The following is a description of a gene set: In normal human plasma, thrombin cleaves factor VIII (FVIII) after arginine residues 391 (A1-A2 domain junction) and 759 (A2-B domain junction) to yield heavy chain fragments and at R1708 (a3-A3 junction) to yield the light chain fragment (Eaton D et al. 1986; Hill-Eubanks DC et al. 1989). Mutations affecting arginine residues located at the thrombin cleavage sites of factor VIII protein result in mild/moderate hemophilia A (HA) (Pattinson JK et al. 1990; Arai M et al. 1990; Schwaab R et al. 1991). part of: Defective factor VIII causes hemophilia A Reactome Pathway: Defective F8 cleavage by thrombin studied in species Homo sapiens, and this is the list of marker genes: F2, VWF, F8